Given this list of marker genes Tmem184b, Septin7, Adcy1, Ptk2, Mark2, Sh3bp4 (NCBI Gene Id 98686), Zfp275, Chd6, Cox16, Adcyap1r1, Zfp93, Smg1, Or10ad1, Mlxip, Gmnc, Xpo7, Rbm11, Irgm1 (immunity-related GTPase family M member 1), Eno1, Zfp131, Tmem39b (NCBI Gene Id 76144), Slc35a4, Tapt1, Nubp1, Zbtb39, Arsk, Adgrl1, Pmp2, Uimc1, Kpna3, Braf, Man1a, Smurf1, C2cd2, Zfp467, Grap2, Bnc2, Sox12, Med26, Urm1, Snta1, Gdpd4, Mecp2, Foxp4, Cpne1, Pcnp, Dcaf1, Aak1, Hey2, Bahcc1, Zfat, Fadd, Pqbp1 (NCBI Gene Id 631302), Tfrc, Mttp, Ranbp10, Tmem178b, here is a description of the gene set: Mouse Gene Set: MIR_6769B_5P studied in species Mus musculus from publication Chen Y, Wang X (PMID 31504780) Genes predicted to be targets of miRBase v22 microRNA mmu_miR_6769b_5p in miRDB v6.0 with MirTarget v4 prediction scores > 80 (high confidence targets).